Given this list of marker genes HDAC8, HDAC11, HDAC1, HDAC4, HDAC5, SIRT1, HDAC2, HDAC7, HDAC6, SIRT6, HDAC9, HDAC3, here is a description of the gene set: Catalysis of the reaction: H2O + N6-acetyl-L-lysyl- = acetate + L-lysyl-. species: Homo sapiens Human Gene Set: GOMF_HISTONE_DEACETYLASE_ACTIVITY_HYDROLYTIC_MECHANISM